Given this list of marker genes SERPINA3, MAP1A, LRRC17, IGLC7, CFLAR, SIRPB1, FBN2, AEBP1, FUT3, KRT6A, TRIB1, MMP2, HYAL2, CETN1, TMEM94, LIMK2, PSG11, NELL2, ODF1, CCL7, CDH8, CELA3A, NHLH1, BBS9, ATM, FLNA, GLI3, SIGMAR1, TH, GSTP1, FEV, CCR9, AR, COL11A1, NOP14-AS1, here is a description of the gene set: Human Gene Set: OUELLET_CULTURED_OVARIAN_CANCER_INVASIVE_VS_LMP_DN from publication Ouellet V, Provencher DM, Maugard CM, Le Page C, Ren F, Lussier C, Novak J, Ge B, Hudson TJ, Tonin PN, Mes-Masson AM (PMID 15940270) studied in species Homo sapiens Tumors of low malignant potential (LMP) represent 20% of epithelial ovarian cancers (EOCs) and are associated with a better prognosis than the invasive tumors (TOV). Defining the relationship between LMPs and TOVs remains an important goal towards understanding the molecular pathways that contribute to prognosis, as well as providing molecular markers, for these EOCs. To this end, DNA microarray analyses were performed either in a primary culture or a tumor tissue model system and selected candidate genes showing a distinctive expression profile between LMPs and TOVs were identified using a class prediction approach based on three statistical methods of analysis. Both model systems appear relevant as candidate genes identified by either model allowed the proper reclassification of samples as either LMPs or TOVs. Selected candidate genes (CAS, CCNE1, LGALS8, ITGbeta3, ATP1B1, FLIP, KRT7 and KRT19) were validated by real-time quantitative PCR analysis and show differential expression between LMPs and TOVs. Immunohistochemistry analyses showed that the two tumor classes were distinguishable by their expression of CAS, TNFR1A, FLIP, CKS1 and CCNE1. These results define signature patterns for gene expression of LMPs and TOVs and identify gene candidates that warrant further study to deepen our understanding of the biology of EOC. Genes down-regulated in pirmary cultures of epithelial ovarian cancer (EOC): invasive (TOV) vs low malignant potential (LMP) tumors.